The following is a description of a gene set: Human Gene Set: HP_ABNORMALITY_OF_THE_EPIPHYSES_OF_THE_PROXIMAL_PHALANGES_OF_THE_HAND Abnormality of the epiphyses of the proximal phalanges of the hand species: Homo sapiens, and this is the list of marker genes: RAB23, GDF5, TRPS1, NPR3, IHH